The following is a description of a gene set: studied in species Mus musculus Mouse Gene Set: GOBP_ACTIVATION_OF_PROTEIN_KINASE_B_ACTIVITY Any process that initiates the activity of the inactive enzyme protein kinase B., and this is the list of marker genes: Ang, Notch2, Ang6, Itgb1bp1, Ins2, Gas6, Adra2b, Slc1a1 (solute carrier family 1 (neuronal/epithelial high affinity glutamate transporter, system Xag), member 1), Ntrk3, Mt3, Igf1, Tm9sf5, Ntf3, Tcl1, Insr, Dynapl1, Adra2a, Ang5, Ins1, Ppia, Ang2, Dynap, Nrg1, Adra2c, Wnt5a, Ang4, Fgf1